The following is a description of a gene set: Mouse Gene Set: REACTOME_FGFRL1_MODULATION_OF_FGFR1_SIGNALING FGFRL1 modulation of FGFR1 signaling studied in species Mus musculus, and this is the list of marker genes: Fgf23, Fgf17, Fgf2, Fgf4, Fgfrl1, Fgf22, Fgf3, Fgf5, Fgf10, Spred1, Spred2, Fgf18, Fgf8